Given this list of marker genes DONSON, CDC42, RBM28, CNOT2, UBE4B, HIC1, EIF4H, PIGN, BRCA1, MAPRE2, MGAT2, MCTP2, PACS1, RIT1, IFT122, PRDM16, MED25, SPECC1L (NCBI Gene Id 8221), SPEN, DPYSL5, NIN, COG8, BUB1B, KIAA0753, BMP2, BCOR, DVL1 (NCBI Gene Id 348497), KCNH1, ZC4H2, STAG1, COG1, DDX11, ELN, H4C3, BBIP1, KIFBP, BRIP1, MKKS, NFIX (NCBI Gene Id 4784), IHH (Indian hedgehog signaling molecule), CDC45 (NCBI Gene Id 8319), MASP1, HOXA13, RAI1, GJA1, GATA6, CENPE, ROR2, CHD8, PEX1, MAFB, REV3L, FGFR2, CUL7, BPTF, MUSK, PRKDC, TMEM216, SATB2, BBS7, PIGL, IFT74, BUB1, LEMD3 (LEM domain containing 3), FANCI (NCBI Gene Id 751608), IFT140, PTRH2, NKX2-5, NALCN, SRCAP, BAZ1B, AP1G1, TBX5, LTBP1, CAPRIN1, BBS1, AKT1, ATR, ORC1, DOK7, BLM, IGF2, CHST3, TRAPPC9, EVC2, MLXIPL, PKDCC, GTF2IRD2, SH3PXD2B, EXT2, COL9A1, BBS5, NEK1, ATP6V1B2, SLX4, FANCB, SIN3A, FBN2, FRA10AC1, CFAP418, TRIP13, BGN, PIK3CD, CRLF1, GTF2IRD1, TRPV4, DPF2, MAN1B1, YY1AP1 (NCBI Gene Id 55249), PHF21A, CUL4B, BBS9, DHPS, ALX3, MECOM, AMMECR1, NAA10 (N-alpha-acetyltransferase 10, NatA catalytic subunit), NKX3-2, KMT2B, SMC3, ORC4, MAPK8IP3, KPTN, UBA2, WDR19, RNU4-2, KDM4B, TPM2, KMT2A, CTCF, CLCN3, POLA1, CD96, HNRNPK, CDT1, H3-3B, TTC8, USP7, EP300, OFD1, ZMYM2, CSGALNACT1, SALL4, TAF4, SCAPER, DLX3 (distal-less homeobox 3), IGF1, GLI3, PTPN11, QRICH1, BICD2, CCDC28B, COL9A3, ERI1, GJA5, NRAS, YWHAE, LMX1B, WDR35, ARID1B, SLC9A7, UBE2T, SKI, TWIST2, KRAS, PHGDH, MYBPC1, HDAC4, WDR4 (WD repeat domain 4), OPA3 (outer mitochondrial membrane lipid metabolism regulator OPA3), FAM149B1, MKRN3, PIGH (NCBI Gene Id 5283), PLOD3, AFF2, PTH1R, BUB3, PPP2R1A, FKBP6, BMP4, CBL, ZEB2, ABCC8, CCDC22, HEATR3, PACS2, LIFR, ORC6, DNA2, FANCL, ATN1, FLII, PIGY (NCBI Gene Id 84992), WNK3, SIK3, DYM, GATA5 (GATA binding protein 5), CEP57, BRAT1, SETBP1, MOGS, DPAGT1, OTUD5, NSD2, ABL1, BRCA2, SALL1, CASZ1, TWIST1, ALDH1A2, TCTN3, RAD51, TRAIP, SOX4, NCF1, TCF4, CILK1, COL9A2, SOS1, DSP, PRKACB, MAP3K7, LONP1, SPRED2, POLR1A (RNA polymerase I subunit A), PTF1A, MYCN, PAX3, RYR3, FANCE, COG5, HDAC8, PRR12, MAPK1, SNRPB, MYMK, EIF4A2, MAP1B, MITF, MAD2L2, MKS1, MECP2, MAF, SDCCAG8, TMEM94, CHSY1, SNORD116-1, CCDC8, PLK4, OBSL1, DVL3, NUP37, IFT27, CTU2, SHANK3, LBR, KIF7, NUP85, PDPN, HSPG2, TP63, MMP23B, ALG12, CPLANE1, RAB18, B3GLCT, ALX1, NONO, CSNK2A1, ZNF292, FANCC, CCNQ, TNNT3, MYOD1, NPR2, CCDC47, MEG3, TCF20, H19, LZTFL1, EPB41L1, TRPS1, WNT7A, TNNI2, GMNN, EVC, GNB2, IGF1R, MIA3, KMT2D, COL11A1 (NCBI Gene Id 317718), LMBR1, NOG, GABBR1, BMPR1B, SIAH1, CRKL, NPHP1, MYL11, LMNB2, UBE3B, WDR11, SOX6, ARL6, PDE6D, CEP152, TFAP2A, BHLHA9, CDC6, FGF16, FGFR3, PNPLA6, CHD6, LMNA, NKX2-6, RRAS2, EZH2, HPGD, SLC26A2, L1CAM, ZFPM2, CHST11, HNRNPR, TAF6, BCR, SNRPN, TFAP2B, PIEZO2, ERCC4, FANCA, BBS10, DHCR7, RAB3GAP1, GABRD, WIPI2, EHMT1, ADNP, FANCG, RFC2, KCNJ2, RRAS, COL27A1, DACT1, JUP, NARS2, MADD, SEMA3E, TOPORS, PQBP1, FOXP2, GJA8, SAMD9, SPART, RECQL, SF3B4, SPOP, TMEM231, TRIO, LAMA5, PLXND1, PRKCZ, CREBBP, LIMK1, HOXD13, IFT43, TBC1D24, KDR, CEP55, BBS4, VPS13B, TBX15, RAD51C, PWAR1, PAFAH1B1, ATP2B1, CHRNG, SOS2, ANKRD11, ZIC3, PIK3CA, AMER1, AGO2, MAN2C1, RBM8A, FLT4, METTL27, KDM1A, NSUN2, GPC4, TBL2, MAGEL2, KDM6A, B9D2, ZNF462, CHRNA7, UBE3A, CHD7, COG7, CDH11, DDX59, IFT172, CEP290, FLNA, COMP, TMEM147, RPL10, DLK1, SHOX (SHOX homeobox, NCBI Gene Id 6473), RAD21, SCLT1, LUZP1, EFTUD2 (NCBI Gene Id 9343), GATA4, KDM5A, CRIPT, OGT, ERF, PWRN1, RASA2, ADAMTS15, XYLT1, FZD2, TBX4, XRCC2, TGDS, MACROH2A1, SMAD4, BRF1 (NCBI Gene Id 90137), HMGA2, IKBKG, EIF4A3, TRPM3, GTF2I, GDF1, BUD23, RERE, RAB23, WNT5A, FANCM, SOST, KCTD1, RBBP8 (RB binding protein 8, endonuclease), CCNK, PIGS (phosphatidylinositol glycan anchor biosynthesis class S, NCBI Gene Id 94005), PHIP, STX1A, NEXMIF, TMEM270, IRX5 (NCBI Gene Id 10265), SHH, RFWD3, ACVR1, RSPRY1, ASXL3, PPP1R21, SMC1A, RAF1, PLAG1 (NCBI Gene Id 7996), MYMX, LIG4, RB1, PUF60, ATRX, BLTP1, EBP, ALG9, SPRED1, FLNB, CNOT3, BBS12, KCNK4, MEGF8 (NCBI Gene Id 90198), RECQL4, RNU4ATAC, KDM6B, MRAS, HRAS, PCDHGC4, CKAP2L, ADGRG6, TPR, IQSEC2, BAP1, CEP19, HNRNPH1, HOXA11, ATRIP, STAG2, EMG1, KCNAB2, GRB10, AHDC1, NXN, EBF3, AUTS2, CCDC32, TRAF7, KNSTRN, NEDD4L, XRCC4, RTL1, NAA20, SLC2A10, FAT4, PALB2, RAB11B, BRAF, PITX1, MED12, KCNJ11, FILIP1, NIPBL, ATG7, BPNT2, WDR26, VPS37D, SMOC1 (NCBI Gene Id 64093), NEK9, WDPCP, IFT52, COASY, PAICS, KAT8, BRD4, RAB3GAP2, CANT1, GDF5, PIK3R1, DEAF1, ESCO2, CNOT1, TBX1, KAT6B, SHMT2, MAP2K1 (NCBI Gene Id 5604), MYH3, TRRAP, FGD1, ODC1, TRIM32, KLF13, UBR1, EFNB1, NPAP1, CLIP2, RUNX2 (RUNX family transcription factor 2), RNF216, CITED2, MBD5, GPC3, PCNT, PI4KA, CDKN1C, FANCD2, CNTN1, BBS2, MEF2C, JAG1, TELO2, SNORD115-1, HERC2, TBX22, DNAJC30 (DnaJ heat shock protein family (Hsp40) member C30), FANCF, SMARCA2, LZTR1, here is a description of the gene set: Human Gene Set: HP_DEVIATION_OF_THE_HAND_OR_OF_FINGERS_OF_THE_HAND Displacement of the hand or of fingers of the hand from their normal position. Deviation of the hand or of fingers of the hand species: Homo sapiens